Given this list of marker genes RAD23B, RALBP1, SOAT1, HOXC8, TRIM41, FLYWCH1, OSGIN1, MRPL45, PGAM1, SON, AARS1, NFIL3, MORF4L1, SMPD2, NUFIP1, OGDH, SPICE1, RMC1, RECQL, INPP5D, SPN, MFSD6, POGLUT2, PROCR, GRIPAP1, SLC1A5, EIF4G2, PDLIM7, INTS6L, CXCL16, SRD5A3, GJC1, C9orf72, CYB5A, FBXW4 (NCBI Gene Id 6468), CYFIP1, PAM16, GTF2H2, MMUT, DNMBP, ACSL5, ANKRD24, EPB41, IFT57, SMIM3, MFAP1, ZNF524, AP2A2, WDTC1, MRPL4, AVPI1, DDRGK1, PSEN2, GDI2, FOS, PTPN14, IL10, TULP3, FBXO38, NAA38, BMAL2, DNAJB1, CMTR2, DHRS7B, SREK1IP1, ADNP2 (NCBI Gene Id 22850), KDM3A, ATF6B, CREG1, COQ9, SLC38A2, PAQR7, GDI1, CDK8, RGL2 (ral guanine nucleotide dissociation stimulator like 2), RD3, ZDHHC6, TERT, MED28, SARS1, SLC9A8, POLR2B, KHDC4, GMFG, OR6A2, AAGAB, RNMT, FCER1G, GSTM5, CPEB2, ZNF830, TTC3, DUSP1, GRAMD1A, GRINA, PPIC, JUN, HDAC5, AOPEP, CEP20 (NCBI Gene Id 123811), CDC23, HACD4, SLC25A19 (NCBI Gene Id 60386), ALOX5AP, ARC, IFT70A, TUBB2B, ROR1, B3GAT3, WDFY3, RRAD, ENPP2, MOCS2, AKIRIN2, MEPCE, MRPL41, DDB2, IFNAR2, ADAM9, PNKD (NCBI Gene Id 87830), SIL1, TM6SF1, STAG1, ZBTB2, ANTXR1, USP5, KLC2, TRIAP1, ZNF124, HGS, C1GALT1C1, DDX6, POR, ZFP36L1, FASTKD2 (NCBI Gene Id 22868), SNTA1, SLC39A13, TEPSIN, ZBTB25, BDH1, ANAPC5, ABCC5, SASH1, WDR45B, SLC26A7, DNER, DGUOK, ATP13A2, LCE2B, RFC1, MGAT2, SLC25A20, RPP25L, C6orf136, CDK5RAP1, TMLHE, MOAP1, XRCC6, MRFAP1L1, ABCB7, STAT4, PDIK1L, DCAF4, DALRD3, NRIP1, TECPR1, IGBP1, VPS26C, SLA, DENND2D, RNF103, DNAJC12, NPEPPS (NCBI Gene Id 9520), IMPDH2, MRE11, ZYG11B, CCT6A, PLIN2, GTF3C1, NDUFAF7, AMACR, TRIM27, MIF4GD, KCMF1, COPG2, EGR2, RNPS1, PEX19, ZDHHC16, MNT, NDUFB3, MYDGF, MMP9, HCFC1R1, PAK1IP1, DELE1, PLTP, SOS2, LYL1, SEC24D, here is a description of the gene set: from publication Amit I, Garber M, Chevrier N, Leite AP, Donner Y, Eisenhaure T, Guttman M, Grenier JK, Li W, Zuk O, Schubert LA, Birditt B, Shay T, Goren A, Zhang X, Smith Z, Deering R, McDonald RC, Cabili M, Bernstein BE, Rinn JL, Meissner A, Root DE, Hacohen N, Regev A (PMID 19729616) mouse primary BMDCs were stimulated with tlr ligands and gene expression changes were profiled on Affymetrix arrays studied in species Homo sapiens Genes down-regulated in comparison of dendritic cells (DC) stimulated with CpG DNA (TLR9 agonist) at 4 h versus those stimulated with CpG DNA (TLR9 agonist) at 24 h. Human Gene Set: GSE17721_4_VS_24H_CPG_BMDC_DN